Given this list of marker genes Tcf7, Tcf7l2, Hdac1, Ctnnb1, Lef1, Sin3a, Hint1, Tcf7l1, here is a description of the gene set: studied in species Mus musculus Mouse Gene Set: REACTOME_REGULATION_OF_MITF_M_DEPENDENT_GENES_INVOLVED_IN_CELL_CYCLE_AND_PROLIFERATION Regulation of MITF-M-dependent genes involved in cell cycle and proliferation